The following is a description of a gene set: species: Homo sapiens Hypercortisolemia associated with a primary defect of the adrenal gland leading to overproduction of cortisol. Human Gene Set: HP_PRIMARY_HYPERCORTISOLISM Primary hypercortisolism, and this is the list of marker genes: MEN1, CDKN1B (NCBI Gene Id 1027), GNAS, PDE11A, PRKAR1A, CDKN1A, CDKN2B, CDKN2C (NCBI Gene Id 654235), PRKACA